The following is a description of a gene set: The Roundabout (ROBO) family encodes transmembrane receptors that regulate axonal guidance and cell migration. The major function of the Robo receptors is to mediate repulsion of the navigating growth cones. There are four human Robo homologues, ROBO1, ROBO2, ROBO3 and ROBO4. Most of the ROBOs have the similar ectodomain architecture as the cell adhesion molecules, with five Ig domains followed by three FN3 repeats, except for ROBO4. ROBO4 has two Ig and two FN3 repeats. The cytoplasmic domains of ROBO receptors are in general poorly conserved. However, there are four short conserved cytoplasmic sequence motifs, named CC0-3, that serve as binding sites for adaptor proteins. The ligands for the human ROBO1 and ROBO2 receptors are the three SLIT proteins SLIT1, SLIT2, and SLIT3; all of the SLIT proteins contain a tandem of four LRR (leucine rich repeat) domains at the N-terminus, termed D1-D4, followed by six EGF (epidermal growth factor)-like domains, a laminin G like domain (ALPS), three EGF-like domains, and a C-terminal cysteine knot domain. Most SLIT proteins are cleaved within the EGF-like region by unknown proteases. NELL2 is a ligand for ROBO3.<br><br>SLIT protein binding modulates ROBO interactions with the cytosolic adaptors. The cytoplasmic domain of ROBO1 and ROBO2 determines the repulsive responses of these receptors. Based on the studies from both invertebrate and vertebrate organisms it has been inferred that ROBO induces growth cone repulsion by controlling cytoskeletal dynamics via either Abelson kinase (ABL) and Enabled (Ena), or RAC1 activity. While there is some redundancy in the function of ROBO receptors, ROBO1 is implicated as the predominant receptor for axon guidance in ventral tracts, and ROBO2 is the predominant receptor for axon guidance in dorsal tracts. ROBO2 also repels neuron cell bodies from the floor plate.<p>In addition to regulating axon guidance, ROBO1 and ROBO2 receptors are also implicated in regulation of proliferation and transition of primary to intermediate neuronal progenitors through a poorly characterized cross-talk with NOTCH-mediated activation of HES1 transcription.<p>Thalamocortical axon extension is regulated by neuronal activity-dependent transcriptional regulation of ROBO1 transcription. Lower neuronal activity correlates with increased ROBO1 transcription, possibly mediated by the NFKB complex.<p>It is suggested that the homeodomain transcription factor NKX2.9 stimulates transcription of ROBO2, which is involved in regulation of motor axon exit from the vertebrate spinal code.<p>Of the four ROBO proteins, ROBO4 is not involved in neuronal system development but is, instead, involved in angiogenesis. The interaction of ROBO4 with SLIT3 is involved in proliferation, motility and chemotaxis of endothelial cells, and accelerates formation of blood vessels. part of: Axon guidance Reactome Pathway: Signaling by ROBO receptors studied in species Homo sapiens, and this is the list of marker genes: RPL39L, RPL37, DAG1, PRKACG, FLRT3, PAK5, AKAP5, RPL27, FAU, SLIT1, RPLP1, CDC42, SLIT2, RPL21, NCK1, NCK2, EIF4A3, UBB, RPL23A, RHOA, RPS4X, SRGAP1, RPS29, RPS3A, NRP1, ROBO2, PAK1, RPS16, RPL14, RPL11, LHX3, RPL26, PSMC2, RPL27A, RPS15A, RPL26L1, LHX9, ROBO1, PSMD14, PSMD3, RPL7, RPL10L, 28S rRNA, PSMA3 (NCBI Gene Id 5684), RPL17, RPL24, SOS1, DCC, ADRM1, ABL2, EIF4G1, PSMD6, MYO9B, RPL35A, RPS17, LDB1 (LIM domain binding 1), PAK4, LHX2, UPF3B, RPS25, RPL35, RPL9, CAP2, CXCR4, ELOB, RBX1, RPS21, SOS2, COL4A5 (NCBI Gene Id 1287), RPL18A, RPL31 (NCBI Gene Id 6160), RPL13 (ribosomal protein L13), PSMB1, RPSA, VASP, RPL22L1, RPS11, RPS4Y2, PRKCA, RPL4, PSMD8, UBC, RPS4Y1, RBM8A, PSMD13, RPL39, PSMD11, UPF2, RPL18, RPS3, RPL36, PSMD1, NELL2, RPL6, GPC1, ROBO3.1, ELOC, RPS6, RPS8, RPL15, RPS23, NCBP1, SLIT3 (slit guidance ligand 3), PRKACB, 5S rRNA, RPL34, RPS20, EVL, USP33, SEM1, RPL10A, RPL23, PSMB5, RPL12, PSMB3, GSPT2, SRGAP2, RPL3L, RPL3, ROBO3, MSI1, RPS24, MAGOH, RPS28, PABPC1, RPS7, CAP1, PSMB6, RPL38, PSMC5, RPS9, PRKAR2A, RPL28, MAGOHB, PRKACA, RPS10, RPL32, RPL30, UPF3A, CUL2, RPL36AL, CXCL12, LHX4, RPS14, RNPS1 (RNA binding protein with serine rich domain 1), RPL8, PAK6, PPP3CB, 18S rRNA, RPS27L, ABL1, UBA52, RPL41, PAK2, PSMB2, RPS5, RPS12, RPL37A, RPL10, CLASP1, RPS27, RPL13A, RPL36A, RPL19, CLASP2, PSMA7, ETF1, ENAH (ENAH actin regulator), PSMB4, 5.8S rRNA, PSMD7, PSMA5, RPL5, PSMD2, SRC, PSMA6, PSMA4, PAK3, RPL7A (NCBI Gene Id 6130), PSMC4, RPLP0, NCBP2, CASC3, RPS27A, PSMC3, RPLP2, ZSWIM8, PFN1, PSMC1, ISL1, RPS2, PSMB7, HOXA2 (homeobox A2), PSMC6, PFN2, GSPT1, PSMA2, SRGAP3, PSMA1 (NCBI Gene Id 5682), NTN1, ARHGAP39, RPS15, RPS26, RPL29, RAC1, PSMD12, RPS19 (NCBI Gene Id 8378), RPS13, RPS18, RPL22